Given this list of marker genes IRF5, SLC22A4, TNFAIP3, BMP2, TRPV4, BLK, CCN6, ELP1, BANK1, ETS1, COL11A1, BMP6 (NCBI Gene Id 7964), P4HA2, NFKBIL1 (NFKB inhibitor like 1), HGD, C4B, CTLA4, PXK, IL10, TNFSF4, FCGR3B, COL2A1, IL6ST, TREX1, KIAA0319L, HLA-DPA1, HLA-DRB1, NLRP3, IRAK1, HJV, PTPN22, ITGAM, DNASE1, DOCK11, IGHG1, CIITA, HPGD, HLA-DPB1, MECP2, ENPP1, C4A, DMP1, PRG4, STAT3, TNIP1, HLA-B, UBE2L3, NOD2, SAMHD1, TNFRSF1A, HAMP, SPTLC1, NGF, IL36RN, TLR7, CR2, JAZF1, NTRK1, HFE, CD244, ANKH (NCBI Gene Id 7995), F8, STAT4, MMP14, MMP2, SPP1, ATL1, NLRP1, SPTLC2, PDCD1, ATL3, MEFV, DNASE2, CHST3, ALPL, FCGR2B, PRTN3, PIK3CD, here is a description of the gene set: studied in species Homo sapiens Arthropathy Human Gene Set: HP_ARTHROPATHY